Given this list of marker genes Surf1, mt-Co3, Cox4i2, Cox7a1 (NCBI Gene Id 12865), Cox5a, mt-Co1, mt-Co2, here is a description of the gene set: Mouse Gene Set: GOMF_CYTOCHROME_C_OXIDASE_ACTIVITY Catalysis of the reaction: 4 ferrocytochrome c + O2 + 4 H+ = 4 ferricytochrome c + 2 H2O. species: Mus musculus